Given this list of marker genes SFR1, HSP90AA1, ZNF366, CD24, SP1, RARA, PRKAA1, NCOA4, TRIM24 (tripartite motif containing 24), OPRK1, CRHBP, KMT2D, CDK12, HOXA10, GAL, KRT19, CLDN18, SERPINB9, GHRHR, MSTN, ABCC9, ASH2L, AR, CTNNA1, CITED2, CCND1, BCAS3, MMP14, BGLAP, GBA1, CAV1, RBBP5, SLC34A2, HOXA11, MME, CRH, EPO, WNT7A, ARSB, ARPC1B, SMAD6, MDM2, SRD5A1, ARID5A, TRIM25, IGFBP2, GHRL, GATA3, CYP27B1, WBP2, RCAN1, SFRP1, MIR493, CITED4 (NCBI Gene Id 163732), ESR1, DHH (NCBI Gene Id 791256), F7, GATA6, EP300, SLC10A1, CITED1, GSTM3, PELP1, OCSTAMP, MMP2, here is a description of the gene set: Human Gene Set: GOBP_RESPONSE_TO_ESTROGEN studied in species Homo sapiens Any process that results in a change in state or activity of a cell or an organism (in terms of movement, secretion, enzyme production, gene expression, etc.) as a result of stimulus by an estrogen, C18 steroid hormones that can stimulate the development of female sexual characteristics.